The following is a description of a gene set: Human Gene Set: OCT1_B Genes having at least one occurrence of the motif TATGCAAATN in the regions spanning 4 kb centered on their transcription starting sites. This matches the POU2F1 transcription factor binding site V$OCT1_B (v7.4 TRANSFAC). studied in species Homo sapiens, and this is the list of marker genes: CADM1, NRAS, SCOC, NEUROD6 (NCBI Gene Id 63974), DUSP6, SLC1A2, NFIA, SPIB, EGR2, TBR1, LIPG, HOXC5, MED16, E2F3, TMCC1, OTX2, H2BC21, H2AC4, ADORA1, CLCA3P, HORMAD2, GFI1B, SLC24A1, DMD, BCO2, FES, HOXB6, CDX4 (NCBI Gene Id 1046), ETV1, DLGAP4, SKIL, ADORA2A, THRA, SLC25A35, H3-3B, GRHL3, HPCAL4, C12orf57 (NCBI Gene Id 113246), ZBTB32, CRACR2B, TSC22D3, H2AC20, SLC19A3, STAT4, CRYZL1, KLF12, OPA3, CD79B, PRKG1, LRCH4, SCML4, WNT6, TSPAN13, NR1D1, MITF, RHOBTB2 (Rho related BTB domain containing 2), IQCB1, TAS2R13, BCL2, CHD6, PTHLH, SLC6A15, CEP41, UBE2S, MGAT5B, VSTM2A, HOXA10, CDX2, ZNF516-DT, VPREB3, LRRTM4, PIK3CD, LCOR, BCORP1, GPRC5B, ASCL3, ITSN1, IGSF21, TMSB4XP8, PLXNA2, TRPM1, PFKFB1, APOBEC4, SH3BGRL, H2BC3, MYBPC1, NSMCE3, TCEAL1, TAS2R40, CPD (carboxypeptidase D), PTEN, EBF1, LHX6, COL23A1, PCYT1B, VGLL3, PPARGC1B, GAB2, LRRN1, SPTY2D1, CRISP1 (NCBI Gene Id 167), SRF, MID1, FZD2, TBXAS1 (NCBI Gene Id 6916), GPC4, EHF, TWIST1, KCTD12, FOXG1, PMEL, TMSB4XP6, COL25A1, DOK3, BIN3, DNAH5, TLL2, LPL, TCF12, PRRC2A, MARF1, PAX6 (paired box 6), TMOD2, ROGDI, SOX2, SREBF2, CD180, STAG1, CSMD3, SFRP2, H3C3, GPR42, TMSB4XP4, ZNF362, C10orf71, PIPOX, C2CD5, HOXA13, MBIP, RAB26, FBXO24, CNNM4, FAM117A (family with sequence similarity 117 member A), CDR2L, GUCA1A, POU3F4, EPHB3, ABTB2, CSRNP1, SPRR2B, KANSL1L, NR2C2, UQCC2, DLG2, EAF2, TAS2R4, FGF14, CADM2, CDK2, PCDH20 (protocadherin 20), BDNF, CACNA1C, FGF12, H2BC14, NR6A1, RRAS, LDB2, SESN3, POU2F3, ZNF428, NFYB, H2BC12, ESRRA, NXPH1, RGL1, H2BC4, HNF1B, CXXC4, IRX4, BLNK, SLITRK6, SKIDA1, NRL, PRDM1, LYN, ITPR3, PRRX1, BTK, PDE4D, HDAC9 (NCBI Gene Id 9734), H3C2, PROKR2, NOTCH1, H2AC14, NRXN3, FOXP1, ALDH1A1, ZHX2, ADNP2, NDP, PATZ1, UPK3A, TRAF3IP2, SUCNR1, RRM2B, SH3GL3, GNB3, JUND, NRXN1, SATB2, CDH13, GPR4, RGS13, MMP1, ARHGAP4, KCTD6, CD86, NDUFA4L2, GPM6A, PLPPR2 (NCBI Gene Id 64748), TSC1, ACBD4 (NCBI Gene Id 79777), MRAS, CSRNP3, ZNF423, LMO3, DPYSL3, POLM (NCBI Gene Id 27434), H2AC6, ARPC5, H2AC21, ARMCX4, PIM2, CSF3, TTI2, VSNL1, AMER1, BEND4, ID3, ATF7IP (NCBI Gene Id 55729), NEUROG1, RHOB (ras homolog family member B), FEZF2, REL (NCBI Gene Id 5966), FSTL5, CCN1, IFIT2, KCNN3, SLC25A12, TP53INP2, SLC39A13, CSNK1E, PPP2R3A, MAP2K6, SERTAD4, SP6, MPPED2, NOS2, OLIG3, MAF, EIF1AX, SYNPR, NEDD4, SIAH3, ACSBG1 (acyl-CoA synthetase bubblegum family member 1), KIF13A, ALK, IL25, H2AC12